Given this list of marker genes Ckmt1, Ckmt2, Ckb, Nme2, Map4k4, Ckm, here is a description of the gene set: Catalysis of the transfer of a phosphorus-containing group from one compound (donor) to a nitrogenous group (acceptor). Mouse Gene Set: GOMF_PHOSPHOTRANSFERASE_ACTIVITY_NITROGENOUS_GROUP_AS_ACCEPTOR species: Mus musculus